The following is a description of a gene set: The presence of a mild form of hearing impairment. Human Gene Set: HP_MILD_HEARING_IMPAIRMENT species: Homo sapiens Mild hearing impairment, and this is the list of marker genes: POLR1A, COL1A2, DPH1, CTSK, MED12, PGM3, MFN2, DPH2